Given this list of marker genes GARIN3, SDHAF1, CDKAL1, TCN2, ABT1, MRM3 (NCBI Gene Id 55178), LINC02139, MOSPD2, PLPPR5-AS1, KIAA2012-AS1, RGCC, SYNPO2, GPRASP3, MFAP3L, LRRCC1, SLC2A13, GPR161, C1QC, SEPTIN7P2, LINC00269, HMGN3-AS1, EPRS1, CAMKV, THAP1, CD27, SPATA31H1, PAPOLG, CLIC4, SLC43A1, GALNT1, AFTPH, RBAKDN, PRSS59P, H3C2, BOK, SMIM15, GXYLT2, VTCN1, DUOX1, PRKAB1, DMD, ZNF597, FAM238B, TSC2, OR5L2, ROBO1, MMP15, TBC1D14, LRRC56, GALNT16, SDHAF2, PNCK, MAST3, TLK2, KNCN, APOE, LINC01620, C4orf46, TMEM59L, JOSD1 (NCBI Gene Id 9929), SEPTIN4, OSER1, EIF1B, TREML1, UBAC1, S1PR3 (sphingosine-1-phosphate receptor 3), PLAAT5, NANOS3, WFDC3, BRINP3, RHBDL2, TOPORS, NKX2-1-AS1, GDPD1, HES1, MADD, SNORA71B, ARG1, INTS14, PKDREJ, SH3PXD2B, CEACAM6, TNFRSF14-AS1, HLA-DPB2, ZFP57, SLC1A2, ARMH3, BIRC2, ARHGAP12, SLC2A10, CDK7, UBAP2L, DAXX, TNFRSF10A, UBE2Z, AMPD1, FMNL2, RNF121 (NCBI Gene Id 95997), HFM1, ALG13, GAPDHS, FCGR1A, DEFB119, SLC39A10, RASSF9, KLHDC3, HIGD1B, MAF1, ITM2C, MTPAP, PALM, SSMEM1, MSL2, GUCY2F, SLC17A4, DPT, NEBL, PCP4, INPP5J, DHX8, EXOSC9, HSPA2, ADM2, ZNF214, BUB3, CAMK2D, SNORA71A, PTP4A1, WWTR1-AS1, FGG, PAK5, LHX2, LINC01553, XIST, ATP1B4, RAB11FIP4, CEACAM21, LINC01549, NAT8B, C11orf71, GHDC, DNAJC14, RNF20, HCN3, SYCP2L, ZNF846, ROS1, FAM124A, CRYBG2 (crystallin beta-gamma domain containing 2), ZNF221, CHMP1B, UPRT, OR5I1, PRSS58, ZRANB1, SDC3 (NCBI Gene Id 9672), LEFTY1, GAL, ZNF765, AVP, KXD1, SREBF2, LIPJ, PLK3, GSDMC, PTPRZ1, HTATSF1P2, LCE3D, PRTG, SLC5A8, ZNF622, TRPV5, RABEP1, GNA12, CMA1, GALNT8, SELENOI, ENDOU, ALDH3B2, ITPRID1, NTM, SCN7A, WWP1, DLGAP3, RTN4, LRATD1, LINC01107, ZNF345, BTBD2, LGR4, NAF1, RPA1, RNF183, here is a description of the gene set: Genes up-regulated in comparison of regulatory T cell (Treg) versus conventional T cells. species: Homo sapiens Human Gene Set: GSE15659_TREG_VS_TCONV_UP from publication Miyara M, Yoshioka Y, Kitoh A, Shima T, Wing K, Niwa A, Parizot C, Taflin C, Heike T, Valeyre D, Mathian A, Nakahata T, Yamaguchi T, Nomura T, Ono M, Amoura Z, Gorochov G, Sakaguchi S (PMID 19464196) Gene expression profiles of subsets of CD4+ T cells according to their expression of FoxP3 and CD45RA were compared. FoxP3 is a key transcription factor for the development and function of natural CD4+ regulatory T cells (Tregs). Here we show that human FoxP3+CD4+ T cells are composed of three phenotypically and functionally distinct subpopulations: CD45RA+FoxP3low resting Tregs (rTregs) and CD45RA-FoxP3high activated Tregs (aTregs), both of which are suppressive in vitro, and cytokine-secreting CD45RA-FoxP3low non-suppressive T cells. The proportion of the three subpopulations characteristically altered in cord blood, aged individuals, and patients with immunological diseases. Terminally differentiated aTregs rapidly die while rTregs proliferate and convert into aTregs in vitro and in vivo as shown by the transfer of rTregs into NOD-scid-common gamma-chain-knockout mice and by TCR sequence-based T cell clonotype tracing in peripheral blood of normal individuals. Taken together, the dissection of FoxP3+ cells into subsets enables one to analyze Treg differentiation dynamics and interactions in normal and disease states, and to control immune responses through manipulating particular FoxP3+ subpopulations.